Given this list of marker genes Ap1b1, Aftph, Ap1m2, Ap1s3, Ap1s2, Ap1g2, Ap1s1, Ap1m1, Ap1g1, Clba1, Slc18a3, here is a description of the gene set: Mouse Gene Set: GOCC_AP_1_ADAPTOR_COMPLEX studied in species Mus musculus A heterotetrameric AP-type membrane coat adaptor complex that consists of beta1, gamma, mu1 and sigma1 subunits and links clathrin to the membrane surface of a vesicle; vesicles with AP-1-containing coats are normally found primarily in the trans-Golgi network. In at least humans, the AP-1 complex can be heterogeneric due to the existence of multiple subunit isoforms encoded by different genes (gamma1 and gamma2, mu1A and mu1B, and sigma1A, sigma1B and sigma1C).